The following is a description of a gene set: Mouse Gene Set: MIR_410_3P Genes predicted to be targets of miRBase v22 microRNA mmu_miR_410_3p in miRDB v6.0 with MirTarget v4 prediction scores > 80 (high confidence targets). from publication Chen Y, Wang X (PMID 31504780) studied in species Mus musculus, and this is the list of marker genes: Baz2b, Ahr, Smarca1 (NCBI Gene Id 93761), Tmem108, Wdr82, Mfn1 (mitofusin 1), Tex14, Smad6, Otx2, Klf6, Vegfa, Ptbp3, Pcdh8, Slit3, Chml, Ppfibp1, Osbpl6, Cdk14, Nxpe3, Myh9, Aff4, Usp33, Golm2 (golgi membrane protein 2), Pip5k1b, Tbx4, Kdm6a, Atp8b2, B3glct, Tec, Cldn10, Jrkl, Fgf12, Dnal4, Pbrm1, Gpcpd1, Tbx5, Slc8a1, Zfp644, Boc, Orc6, Tmem106b, Fgfr1op2, Skil, Gad1, Srsf11, Ero1a (endoplasmic reticulum oxidoreductase 1 alpha), Slc6a14, Rreb1, Caps2, Numb, Lrp6, Dlg3, Tent5a, Msi2, Ppp6r1, Bmper, Hipk3, Cdk17, Cobll1, Smad7, Ppp1r2, Med12, Stard13, Nppc, Rere, Cacnb2, Adm, Tent4a, Pla2g4a, Homer1, Pcnx1, Wapl, Mab21l1, Sdr42e1, Nmt1 (N-myristoyltransferase 1), Ezr, Oxr1, Pcdhb17, Sp4, Cpeb4, Pappa2, Sema3e, Prkaa1, Fchsd2, Vat1l, Cbfb, Cd9, Fmr1, Lrp11, Pclaf, Plpp3, Plxna2, Rhag, Lmtk2, 2010106E10Rik, Kat6a, Spin4, Mtus1, Tmx3, Slc25a42, Rasef, Nexmif, Hook3, Frzb, Rp2, Kirrel1, Exoc6, Stk4, Vps26c, Sepsecs, Zfp800, Pgm2l1, Prkar2b, Fancf, Gosr1, Ldlrad3, Sh3glb1, Cdh11, Cdk13, Usp25, Ets1, Med13, Magi3, C9orf72 (NCBI Gene Id 73205), Wdr44, AI182371, Hnf4g, Zbtb34, Naa15, Pde4b, Btf3l4, Taf7, Rgmb, Gpr160, Gucy1a2, F11r, Ndfip2, Osbpl3, Arid2, Socs4, Bmpr2, Zbtb44, Htr5a, Spink11, Rc3h2, Fut9, Arid5b, St8sia4, Blzf1, Gfpt1, Ptpn21, Wnt5b, Rock2, Zeb2, Zfp712, Zbtb41, Smc2, Zfx, Zswim6, Styx, Adcyap1, Gabpb2, Hace1, 4921517D22Rik, Map2, Trappc3, Pik3ip1, Cnr1, Wnt3, Gpr155, AI593442, Ermp1, Tcf7l2, Htr1f, Pde4d, Armc8 (NCBI Gene Id 74125), Chic2, Itga2, Prr11, Prrx1, Tnfsf11, Irak3, Dock9, Eml1, Erbin, Pcsk5 (NCBI Gene Id 18552), Dcdc2a, Nr3c1, Nrde2, Epb41l2, Sp3, Ddit4l (NCBI Gene Id 78637), Hivep1, Clec4d, Creb5, Erg, Slc37a1, Serbp1, Jmy, Rc3h1, Ripor2, Pabpc4l, D16Ertd472e (NCBI Gene Id 69342), Rnf138, Rora, Lcorl (NCBI Gene Id 338482)